Given this list of marker genes GNA15, CHRM3, CHRM4, RGS10, GNAI2, RGS8, AGRN, GRK2 (G protein-coupled receptor kinase 2), CDK5R1, CHRM5, PRKCB, PLCB1, HRH3, HRH4, CHRM2, ITPR1, GNA11, GNAQ, GNB1, OPRM1, CHRM1, here is a description of the gene set: A G protein-coupled receptor signaling pathway initiated by a ligand binding to an acetylcholine receptor on the surface of a target cell, and ends with regulation of a downstream cellular process, e.g. transcription. Human Gene Set: GOBP_G_PROTEIN_COUPLED_ACETYLCHOLINE_RECEPTOR_SIGNALING_PATHWAY studied in species Homo sapiens